Given this list of marker genes FJX1, CLEC16A, MIRLET7A3, ZNF445, MIR22HG, EMC10, CDK5R1, BSN, SLC17A7, MIR9-2HG, USP7, SNORA74A, B3GAT1, MIR29B2, TRAK1, AOPEP, here is a description of the gene set: species: Mus musculus Individuals with 22q11.2 microdeletions show behavioral and cognitive deficits and are at high risk of developing schizophrenia. We analyzed an engineered mouse strain carrying a chromosomal deficiency spanning a segment syntenic to the human 22q11.2 locus. We uncovered a previously unknown alteration in the biogenesis of microRNAs (miRNAs) and identified a subset of brain miRNAs affected by the microdeletion. We provide evidence that the abnormal miRNA biogenesis emerges because of haploinsufficiency of the Dgcr8 gene, which encodes an RNA-binding moiety of the 'microprocessor' complex and contributes to the behavioral and neuronal deficits associated with the 22q11.2 microdeletion. from publication Stark KL, Xu B, Bagchi A, Lai WS, Liu H, Hsu R, Wan X, Pavlidis P, Mills AA, Karayiorgou M, Gogos JA (PMID 18469815) Genes located outside the microdeletion region in 22q11 which were differentially expressed in the same manner both in hyppocampus and prefrontal cortex. Human Gene Set: STARK_BRAIN_22Q11_DELETION